Given this list of marker genes GPRC5A, MPP2, BCL2L1, LBH, SLC16A3, ACTN4 (NCBI Gene Id 81), SRM, CTNND1, TRPC4AP, TLE5, ZFP57, PLOD2, CARM1, ITGA5, LSM2, CITED2, KDM3A, MED15, SELENOW, CNOT3, FSCN1, RNF126, PPM1G, JUND, ATN1, COL6A2, NGF, MYBBP1A, DUSP10, IP6K2, PRSS35 (NCBI Gene Id 167681), ABCF2, HK1, F2RL1, MARK2, here is a description of the gene set: Genes up-regulated by hypoxia in TRAMP-C cells (prostatic cancer) expressing HIF1A and FOXA2 off plasmid vectors. Human Gene Set: QI_HYPOXIA_TARGETS_OF_HIF1A_AND_FOXA2 Neuroendocrine (NE) phenotype, seen in >30% of prostate adenocarcinomas (PCa), and NE prostate tumors are implicated in aggressive prostate cancer. Formation of NE prostate tumors in the TRAMP mouse model was suppressed in mice lacking the ubiquitin ligase Siah2, which regulates HIF-1alpha availability. Cooperation between HIF-1alpha and FoxA2, a transcription factor expressed in NE tissue, promotes recruitment of p300 to transactivate select HIF-regulated genes, Hes6, Sox9, and Jmjd1a. These HIF-regulated genes are highly expressed in metastatic PCa and required for hypoxia-mediated NE phenotype, metastasis in PCa, and the formation of NE tumors. Tissue-specific expression of FoxA2 combined with Siah2-dependent HIF-1alpha availability enables a transcriptional program required for NE prostate tumor development and NE phenotype in PCa. from publication Qi J, Nakayama K, Cardiff RD, Borowsky AD, Kaul K, Williams R, Krajewski S, Mercola D, Carpenter PM, Bowtell D, Ronai ZA (PMID 20609350) species: Mus musculus